The following is a description of a gene set: part of: Negative regulation of the PI3K/AKT network This event has been computationally inferred from an event that has been demonstrated in another species.<p>The inference is based on the homology mapping from PANTHER. Briefly, reactions for which all involved PhysicalEntities (in input, output and catalyst) have a mapped orthologue/paralogue (for complexes at least 75% of components must have a mapping) are inferred to the other species. species: Mus musculus Reactome Pathway: PI5P, PP2A and IER3 Regulate PI3K/AKT Signaling electronically inferred by orthology from the curated human pathway, and this is the list of marker genes: Il33, Fgf7, Pdgfa, Nrg3, Mapk3, Ier3, Erbb2, Fgfr1, Pik3r2, Fgf2, Fgf20, Ppp2r5a, Fgf10, Kitl, Fgf16, Gab1, Pip5k1c (phosphatidylinositol-4-phosphate 5-kinase, type 1 gamma), Trat1, Pip5k1a, Lck, Rac2, Fgf1, Il1rl1, Fgf6, Ntf5, Fgf22, Fgf8, Fgf15, Areg, Strn, Erbb4, Ins2, Irak1, Irs2, Grb2, Frs2, Cd19 (NCBI Gene Id 12478), Pik3r5, Egfr, Fgf17, Vav1, Pip4k2c, Tgfa, Esr2, Epgn, Btc, Fgf23, Fgf5, Fgf4, Ppp2r5d (NCBI Gene Id 21770), Fyn, Irs1, Icos, Bdnf, Flt3l, Pdgfrb, Pik3cb, Ins1, Myd88, Kl, Klb (NCBI Gene Id 83379), Cd80, Pdgfb (NCBI Gene Id 18591), Pik3ap1, Kit, Ppp2r5b, Cd28, Ppp2r1b, Esr1, Hgf